Given this list of marker genes H2AC1, SCMH1, UBB, SCML2, PCGF2, BMI1, CBX8, ELOB, RBBP7, CBX6, H2AC4, H3-3A, EPOP, LCORL, PHF19, RNF2, CBX4, PHC2, H3C1, LCOR (ligand dependent nuclear receptor corepressor), RBBP4 (NCBI Gene Id 91125), JARID2, EZH2, PHF1, EZH1, RING1, PHC3, CTBP1, H3C2, CBX7, AEBP2, CBX2, ELOC, PHC1, EED, SCML1, H3-3B, MTF2, SUZ12, CTBP2, here is a description of the gene set: studied in species Homo sapiens Pathway Definition from KEGG: PRC2.1 == (EPOP+ELOB+ELOC),(LCOR,LCORL+CTBP1,CTBP2) -- H3 -> PRC2.2 -- H3K27me3 == cPRC1 -- H2AK119+UB Human Gene Set: KEGG_MEDICUS_REFERENCE_GENE_SILENCING_BY_METHYLATION_OF_H3K27_AND_UBIQUITINATION_OF_H2AK119 Gene silencing by methylation of H3K27 and ubiquitination of H2AK119. Pathway ID: N01577. Pathway type: Reference. Pathway class: nt06523 Epigenetic regulation by Polycomb complexes.